The following is a description of a gene set: Regulation of MITF-M-dependent genes involved in pigmentation Human Gene Set: REACTOME_REGULATION_OF_MITF_M_DEPENDENT_GENES_INVOLVED_IN_PIGMENTATION species: Homo sapiens, and this is the list of marker genes: PMEL, MAPK14, SS18, ACTL6A, ARID1A, TYR, SMARCD3, DPF3, DCT, MLPH, SOX10, MYO5A (NCBI Gene Id 4644), GPR143, ACTB, IRF4, BCL7C, DPF2, SMARCC1, SMARCE1, SMARCA4, MLANA, AKT2, SMARCA2, SYTL2, TYRP1, MYRIP, CTNNB1, MITF, TFAP2A, DPF1, RAB27A, ARID1B, SMARCD1, SS18L1, USF1, CREB1, BCL7A, BCL7B, SMARCB1, SMARCD2, LEF1, SMARCC2